The following is a description of a gene set: Mouse Gene Set: chr1F species: Mus musculus, and this is the list of marker genes: Rgs1, Gm9931, Gm5262, Gm6550, Cfhr4, Gm28392, Gm16332, Cfhr3, Gm5837, Kcnt2, Rgs2, Gm15583, Ro60, Gm7266, Rgs18 (NCBI Gene Id 64214), Cdc73, Gm5834, Cfhr2, Rgs13, Gm29514, F13b, Gm5263, Gm25460, Brinp3, Gm18183, A230059L01Rik, Uchl5, Gm5835, Gm8856, B3galt2, Gm25663 (predicted gene, 25663), Cfhr1, Rbm6-ps2, Glrx2, Rgs21, Gm26048 (NCBI Gene Id 115487652), Gm22681, Gm6397, Gm4845, Cfh, 4930590L20Rik